The following is a description of a gene set: Regulation of TBK1, IKKε (IKBKE)-mediated activation of IRF3, IRF7 studied in species Homo sapiens Human Gene Set: REACTOME_REGULATION_OF_TBK1_IKK_IKBKE_MEDIATED_ACTIVATION_OF_IRF3_IRF7, and this is the list of marker genes: UBA52, RPS27A, OPTN, TLR4, CD14 (NCBI Gene Id 929), TBK1, IKBKE, TICAM1, TANK, LY96, UBC, TRAF3, TICAM2, UBB